The following is a description of a gene set: Human Gene Set: REACTOME_PTK6_EXPRESSION PTK6 Expression species: Homo sapiens, and this is the list of marker genes: NR3C1, EPAS1, PELP1, HIF1A, PTK6